Given this list of marker genes ZNF792, CCR1, RMDN3, PLPPR1, BSDC1, KYNU, PDGFB, PABPN1, NDUFA4L2, GCC2, CDK8, NR4A3, XPNPEP2, CSNK2A2, MLF2, TSC22D1, CCDC71, SEC24B, NR2C1, MAB21L2, LMX1B, GPR52, TTR, MXI1, CNOT9, VCL, HNF1B, OCRL, SEC16B, SCNM1, PABIR1, HOXA2, PIPOX, LRRN1, CNTFR (NCBI Gene Id 1271), FZD7, HNRNPR, HOXC6, OTUD7B, KDM5C, PDC, PNPLA2, GRK5, PTH1R, CLCNKA, SHF, INHBC, FXYD1, LLGL1, MITF, KCNIP2, SLC30A2, SPACA6, FAM170A (NCBI Gene Id 340069), KRT85, STAG2, DIPK2B, G6PC1, MARK2, LRFN3, TMEM120A, RTN2, PDGFRA, LINC00671, GATA4, IER5L, RBMS3, TREH, PRP4K, MAP3K11, NAA20, MREG, PMEPA1 (NCBI Gene Id 56937), SPRY4, PEX16, MYL11, PCBP1, PRRX2, RELCH, PDIA4 (NCBI Gene Id 9601), UBE2K, NR2F1, CCDC80, N6AMT1, S100A14, ZNF70, PPARA, LINS1, ABR, DACT1 (NCBI Gene Id 51339), PPP2R5D, NOG, SATB1, SSH2, RAPGEF4, HOXC4, HOXB6, F12, HNF1A, FGF16, NOVA1, PHLDB3, TIAL1, LMO3, CDK16, RAB3D (NCBI Gene Id 9545), DCN, PCK1, PPIA, ZBTB20, TEF, PLAG1, GBF1, CCDC65, AGPS, ZFYVE1, MYF6, ARFGEF2 (ADP ribosylation factor guanine nucleotide exchange factor 2), TMEM132E-DT, SLC25A51, FAM91A1, C1orf210, NHERF4, BARHL2, DOCK3, S100A16 (NCBI Gene Id 140576), KRTAP19-6, SLC7A7, MAGEH1, OSTC, MSRB1, CDKL5, SELENOP, USP51, PAX6, CUTA, MAPK10, SEMA6A, PLLP, KCNK10, ZNF804A, PRG4, TCF7, FGF10, NUTF2, SMYD5, DUSP3, PLAGL1, COL25A1, JADE2, EIF4G1, PCDH7, MAF, ZBTB12, CCDC88B, SRGAP1, ESAM, NCDN, PRDM1, LHPP, DOCK7, PPARGC1A, CITED2 (NCBI Gene Id 154106), RBP2, HOXD3, STOML2, PAPLN, CLUH, ASB7, HPGD, TMOD2, SRSF6, PODN, ERBB3, RPP21, GOLGA4, DNAJC22, NDST2, RBPMS, ARHGAP33, HOXB9, PACSIN1, DCAF6 (DDB1 and CUL4 associated factor 6), ZCWPW1, ATXN7L2, BRWD3, CDK5R1, ADGRL2, N4BP1, CXCL9, TRPC5, LHX1, MAP3K20, VGF, TAOK3, NRP1, PDZK1, CADM2, NEK6, STK39, TAFA1, DENND6A, CSRNP1, SLC39A5, MEPCE, MAP2K3, TIMELESS, NR2F2, SCHIP1, GPR85, GPAT4, FKBP5, PURA, GGN, MLEC, LEAP2, PID1, TMEM132E (transmembrane protein 132E), MTTP, ACTN3, SMARCD2, GYS2 (NCBI Gene Id 2998), GTF3C2, HHEX, TRAF4, HCAR1, HAT1, RHOBTB1, SLC9A1, ATL1, PALS1, DNAJA2, TP53BP1, GDNF, ADGRB2 (adhesion G protein-coupled receptor B2), TPM1, PFN1, USP37, CNTN6, RREB1, SAP30L, PLA2G12B, ZBTB33 (NCBI Gene Id 10009), LCOR, ANPEP, SLIT3, SLC9A6, TLE1, TARS3, ESRP2, SUPT16H, FOSL1, LRRTM3, RTN4, RBMS1, RNF103 (ring finger protein 103), CLCN5, RBFOX1, BTBD3, ZNF485, PAX7 (paired box 7), CFI, LYSMD1, CHCHD7, SLC26A6, ZDHHC24, DHRS3, GART, SETD2, PAK4, SON, ABCC6, here is a description of the gene set: Genes having at least one occurrence of the motif VTGAACTTTGMMB in the regions spanning 4 kb centered on their transcription starting sites. This matches the HNF4A transcription factor binding site V$HNF4ALPHA_Q6 (v7.4 TRANSFAC). species: Homo sapiens Human Gene Set: HNF4ALPHA_Q6